The following is a description of a gene set: species: Mus musculus Binding to an adrenergic receptor. Mouse Gene Set: GOMF_ADRENERGIC_RECEPTOR_BINDING, and this is the list of marker genes: Adrb1, Pde4d, Adrb3, Magi2, Sh3gl1, Bdkrb2, Akap5, Gria1, Adra2a, Rapgef2 (Rap guanine nucleotide exchange factor (GEF) 2), Arrdc3, Aplp1, Nedd4, Prkar2a, Gnas, Uchl1 (ubiquitin carboxy-terminal hydrolase L1), Dlg4, C1qbp, Adra2c, Arrb2, Arrb1, Nherf1, Ppp2ca